Given this list of marker genes Gamt, Ckb (creatine kinase, brain), Ckmt2, Slc6a7, Ckm, Ckmt1, here is a description of the gene set: part of: Metabolism of amino acids and derivatives studied in species Mus musculus This event has been computationally inferred from an event that has been demonstrated in another species.<p>The inference is based on the homology mapping from PANTHER. Briefly, reactions for which all involved PhysicalEntities (in input, output and catalyst) have a mapped orthologue/paralogue (for complexes at least 75% of components must have a mapping) are inferred to the other species. electronically inferred by orthology from the curated human pathway Reactome Pathway: Creatine metabolism